Given this list of marker genes PTH1R, GPC4, SLC34A2, COL2A1, B3GALT6, ENPP1, EBP, EXTL3, FLNA, LEMD3, CBFB, TONSL, ARSL, PTCH1, BGN, NANS, EXOC6B, SLC35B2, CHST3, RMRP, TRIP11, IHH, MATN3, DDR2, BMPR1B, GDF5, UFSP2, SLC35D1, PIGV, GPC3, FLNB, HOXA13, SLC10A7, TRPV4, XYLT1, PDE4D, CANT1, ABCC6, LONP1, SETD2, MBTPS1, here is a description of the gene set: Abnormal hand bone ossification studied in species Homo sapiens An abnormality of the formation and mineralization of any bone of the skeleton of hand. Human Gene Set: HP_ABNORMAL_HAND_BONE_OSSIFICATION